The following is a description of a gene set: The chemical reactions and pathways resulting in the formation of alcohols, any of a class of compounds containing one or more hydroxyl groups attached to a saturated carbon atom. Human Gene Set: GOBP_ALCOHOL_BIOSYNTHETIC_PROCESS studied in species Homo sapiens, and this is the list of marker genes: PRKAA2, SCAP, ARV1, MIR182, H6PD, SPHK2, DHDDS, ACER2, CYP11B2, CFTR, INSIG2, ACLY, ITPKB, GOT1, P2RY1 (NCBI Gene Id 90963), PRKACA, SPTLC2, MIR548P, CYB5R3, APOE, PCBD2, GNAI1, NUS1, SRD5A3, CD244, CACNA1H, DHFRP1, GCH1, PPIP5K2, IP6K3, ISYNA1, PPIP5K1, PRKAA1, SREBF2, QDPR, FGF1, HMGCS1, BMP5, KPNB1 (NCBI Gene Id 3837), DGKQ, P2RY6, PLPP6, CYP27A1, SPTSSA, CYP51A1, SC5D, MOXD2P, BMP2, IMPA2, SPTLC1, ADCYAP1R1, PMVK, IMPA1, LSS, LIPA, PLCG2, MAPK1, HSD17B7, ACER1, C7orf50, CYP2R1, APOB, PCBD1, DBH, MIR185, MIR342, SPTLC3, SREBF1, HMGCR (3-hydroxy-3-methylglutaryl-CoA reductase), IDI1, INSIG1, REST, ABCA2, G6PD, IPMK, HMGCS2, IP6K1, MVK, PTH1R, LPCAT3, MIR30C1, MVD, ITPKA, DHCR24, IP6K2, MIR96, PTS, GPR146, PCK1, IPPK, SEC14L2, PGP, AGK, IDI2, ASAH2, SCP2, WNT4, CYP7A1, ACER3, MBTPS1 (membrane bound transcription factor peptidase, site 1), TM7SF2, AQP8, SNCA, SPR (sepiapterin reductase), ABCG4, DHFR, ITPKC, DKK3, AVPR1B, ACAA2, PLEK, CES1, CYP27B1, APOA1, SPHK1, CYP11B1, PAQR3, MSMO1, SPTSSB (serine palmitoyltransferase small subunit B), CYP3A4, CLCN2, FDFT1, PARK7, BMP6, FDPS, LEP, MOXD1, MIR98, ERLIN1, NSDHL, PTH, DHCR7, LBR, GPER1, ASAH1, EBP, QKI, NPC1L1, ABCG1, DHRSX, PRKG1, GBA1 (glucosylceramidase beta 1), NTSR1, CYP24A1, MBTPS2, PCK2, ERLIN2, PTAFR, LHCGR, DAB2